The following is a description of a gene set: species: Mus musculus electronically inferred by orthology from the curated human pathway This event has been computationally inferred from an event that has been demonstrated in another species.<p>The inference is based on the homology mapping from PANTHER. Briefly, reactions for which all involved PhysicalEntities (in input, output and catalyst) have a mapped orthologue/paralogue (for complexes at least 75% of components must have a mapping) are inferred to the other species. part of: CLEC7A (Dectin-1) signaling Reactome Pathway: CLEC7A/inflammasome pathway, and this is the list of marker genes: Pycard, Malt1, Casp8